Given this list of marker genes TPP1, ACBD5, HYCC1, ITPR1, BRAT1, SLC19A3, FLVCR1, THG1L, here is a description of the gene set: Truncal titubation Tremor of the trunk in an anterior-posterior plane at 3-4 Hz. Human Gene Set: HP_TRUNCAL_TITUBATION studied in species Homo sapiens